The following is a description of a gene set: Mouse Gene Set: GOMF_PROTEASOME_BINDING species: Mus musculus Binding to a proteasome, a large multisubunit protein complex that catalyzes protein degradation., and this is the list of marker genes: Psmb9, Psme4, Adrm1b, Ubac1, Usp13, Sacs, Uchl5, Ubd, Zfand1, Psmd14, Bag6, Psmg1, Ecpas, Wfs1, Dnajb2, Id1, Usp14, Psmf1, Rad23a, Adrm1, Rad23b